The following is a description of a gene set: species: Homo sapiens Human Gene Set: GOBP_T_HELPER_2_CELL_DIFFERENTIATION The process in which a relatively unspecialized T cell acquires specialized features of a T-helper 2 (Th2) cell. A Th2 cell is a CD4-positive, alpha-beta T cell that has the phenotype GATA-3-positive and produces interleukin-4., and this is the list of marker genes: ASCL2, IL4R, BCL3, SOCS5, PRKCZ, HLX, NLRP3, MYB, IL18, BCL6, CD86, RARA, MEN1, BATF, ANXA1 (annexin A1), KMT2A, TNFSF4, GATA3